Given this list of marker genes LRRC59, NOP2, CCT3, CISD1, CHCHD10, RRP9, MRPL2, ACAD9, SOD2, PGAM1, POLR2F, AIMP2, CDK1, MRPL18, MRPS22, NBN, GCLM, HRAS, COQ5 (NCBI Gene Id 84274), GTF2H4, GMNN, NEURL4, TRIM37, CHERP, CKS1B, CDC20, THAP7 (THAP domain containing 7), NDUFS5, NUP85 (NCBI Gene Id 83705), XPOT, HMBS, DDX1, PLK4, KIF23, NUDT1, CENPK, TPD52L2, BRCA1, LGALS3, CKAP2, GCSH, TSPAN31, RIOX2, TMEM97, MRPL45, MRTO4, MRPS18B, ARMC1, POLR3K, MNS1, NDUFS6, TAMM41, MRPS10, WDR43, SLC19A1 (solute carrier family 19 member 1), IFT27, TIMM9, HAUS4, RHOT1, TMEM109, FAM162A, CYB5B, CRTAP, SIVA1, NDUFAF4, PPA1, PSPH, DCTPP1, RPF2, RFC5, RPA3, RPL7L1, WDR77, DUSP12, HDHD2, MRPL37, TNFRSF9, SYNGR2, MCM5, TAF11, HASPIN, ORC6, RPN1, SRM, CCT6A, JMJD6, NVL, GFM1, CRCP, MTMR9, TPI1, POLR2L, CARM1, MRPL17, HK2, POLR3D, MOGS, ESF1, PAFAH1B2, IDI1, CAD, CD200, ENOPH1, LMNB1, HAX1, IL2RA, ZDHHC16, PDS5B, NCBP2, CCR5, ACOT7, MSMO1, ERG28, LIG1, TUBG1, BLMH, TGDS, RBPJ (recombination signal binding protein for immunoglobulin kappa J region), PLSCR1, RRM1, CNPY2, DCK, IFI30, MCM2, PIGF (phosphatidylinositol glycan anchor biosynthesis class F), CTPS1, RAD51AP1, ELOC, CRABP2, BIRC5, GIT1, MEST, RRP1B, TIMM8A, PHB1, IFNG, KGD4, ARL2, RAD50, NOCT, SERPINB9, GZMB, RCN2, PLP2, MTX2, TNF, RFC2, ARHGEF7, ANLN, GALK1, TRIP13, METTL1, LSM2, GADD45G, TACC3, CLIC4, IRF8 (interferon regulatory factor 8), OLA1, FKBP2, RFC4, IRF4, CSNK2A2, EMC8, BATF3 (basic leucine zipper ATF-like transcription factor 3), PDAP1, SAAL1, POLD2, INO80E, SPR, DTD2, RCC1 (NCBI Gene Id 751867), PSMD12, ABCD3, DHCR7, PDIA4, PRIM2, CARS1, PREP, RBM10, COMT, RNASEH2B (NCBI Gene Id 79621), CINP, DDX52, CKAP5, MAD2L1, MTHFD2, JAGN1, PDCD2, ALDH18A1, XCL1, MKI67, TOP2A, RNH1, CDKN2AIPNL, PTGER4, ELOF1, POLR1A, POLD3, POMP, here is a description of the gene set: Human Gene Set: GSE15930_NAIVE_VS_24H_IN_VITRO_STIM_IL12_CD8_TCELL_DN species: Homo sapiens from publication Agarwal P, Raghavan A, Nandiwada SL, Curtsinger JM, Bohjanen PR, Mueller DL, Mescher MF (PMID 19592655) Differentiation of naive CD8 T cells into cytotoxic effector cells requires three distinct signals- antigen (signal 1), costimulation -B7-1 (signal 2) and cytokine, either interleukin-12 or interferon-a/b (signal 3). Interaction of naive CD8 T cells with antigen and B7-1 programs cell division and proliferation whereas the presence of cytokines- IL-12 or IFNa/b promote survival, differentiation and memory establishment. In the absence of signal 3, the cells interacting with antigen/B7-1 undergo tolerance induction. The objective of this study was to elucidate the mechanisms how the provision of signal 3 promotes differentiation and averts tolerance induction in CD8 T cells. Trichostatin A is a pharmacological agent that inhibits histone deacetylase activity, hence regulating chromatin structure and gene expression and differentiation in many cell types. Gene signature profiles of IL-12, IFNa/b and trichostatin A stimulated cells were compared to elucidate the molecular mechanisms of gene regulation. Oligonucleotide microarray analysis is carried out to determine the extent and molecular nature of the CD8 T cell differentiation program induced by IL-12 or IFNa/b in concert with antigen and B7-1 signal. Genes down-regulated in comparison of CD8 T cells at 0 h versus those at 24 h after stimulation with IL12.